Given this list of marker genes CDKN1A, SLC38A2, ATF2, DEPDC5, RNF152, RRAGC, PEX2, LARP1, EIF2A, SAMTOR, FAS, MAP3K5, ITFG2, SESN2, NPRL3, SEH1L, KICS2, UCP2 (NCBI Gene Id 7351), KPTN, WDR59, SZT2, TRIM32, RRAGD, FLCN, EIF2S1, SESN1, EIF2AK3 (NCBI Gene Id 9451), SAR1A, MTOR, MAPK1, ATXN3, PRKCH, RNF167, NPRL2, MAP1LC3A, ATF4, BECN1, RRAGB (Ras related GTP binding B), WDR24, LARS1, RRAGA, GPR155, SESN3, PRKD1, MAPK8, CASTOR1, TFEB, EIF2AK2, MIOS, SH3GLB1, EIF2AK4, IMPACT, SAR1B, GCN1, ATF3, MAPK3, here is a description of the gene set: studied in species Homo sapiens Human Gene Set: GOBP_RESPONSE_TO_AMINO_ACID_STARVATION Any process that results in a change in state or activity of a cell or an organism (in terms of movement, secretion, enzyme production, gene expression, etc.) as a result of deprivation of amino acids.